Given this list of marker genes LMNB2, LMNB1, LMNA, ICMT, CFD, C3, C5, RCE1, CFB, FNTA, here is a description of the gene set: Human Gene Set: WP_ACQUIRED_PARTIAL_LIPODYSTROPHY_BARRAQUERSIMONS_SYNDROME Acquired partial lipodystrophy / Barraquer-Simons syndrome studied in species Homo sapiens